Given this list of marker genes LAMC2, LAMA1, COL4A5, fimH, COL4A6, LAMB1, COL5A1, COL4A3 (NCBI Gene Id 200750), LAMA2, LAMB2, FN1, COL5A2, COL4A2, papGI, draE, LAMA4, LAMC1, mrkD, UPK1A, COL5A3, LAMB3, EPCAM, csgA, COL4A4, LAMC3, sfaS, LAMA5, COL4A1, LAMA3, here is a description of the gene set: part of: Biofilm formation Physical removal of bacteria from the epithelium is an effective strategy used by the host. It is countered by colonizing bacteria using adhesins that reside on their surface or on pili. Adhesins are the main virulence factors of pathogenic enterobacteria that cause intestinal, bronchial, and urogenital infections. Reactome Pathway: Attachment of bacteria to epithelial cells species: Homo sapiens